The following is a description of a gene set: from publication Chen Y, Wang X (PMID 31504780) species: Homo sapiens Genes predicted to be targets of miRBase v22 microRNA hsa-miR-7856-5p in miRDB v6.0 with MirTarget v4 prediction scores > 80 (high confidence targets). Human Gene Set: MIR7856_5P, and this is the list of marker genes: ARHGAP12, GALNT3, SP3, MRE11, LRIF1, RRAGD, CAMTA1, MCCC2, RWDD2B, SIRT1, DPY19L3, SLC1A4, COPS2, ABCE1, PDCD10, KCNT2, XRN1, UBLCP1, PEX12, DOCK7, KLHL23, HIPK3, NRXN3, SLC12A2, DICER1, ZNF507 (NCBI Gene Id 22847), LRRC19, ZNF414, COBLL1 (cordon-bleu WH2 repeat protein like 1), NUFIP2, TYMSOS, LMBR1, ERBB3, LRAT, ZDHHC21, VPS13C, HEMGN, PRKAA2, THAP2, OGT, CCNJ, TMEM260, GIPC2, PTCHD1, LAMA4, FTMT, ARHGAP18, WDR26, DIXDC1, TMTC4, LIMS1, PTH, SOX9, NANP, USP10, AVL9, QSER1, GLT8D2, KLHL28, FBXO45, VGLL4, CCT8, GPR37, METTL8, GPR22, FSD1L, NEGR1, ZNF705D, CAMK4, GLCE, FZD3, DGKH, VDAC3, NHLH2, PPARGC1B, MAP4K4, MAP3K2, RAB11FIP1, SLC46A3, MOSPD2, USP38, SEH1L, LPAR4, ARK2N, MASP2, FBXO22, RAB3IP, DEFB127 (NCBI Gene Id 140850), AAGAB, GCNT1, MGAT4A, TMTC3, CDH8 (cadherin 8), DARS1, HECTD1, GSS, TWF1, FBXO25, IDE, SMAD5, BMPR2, OARD1, KLF13, ARB2A, GLRB, DDX31, MINDY2, MIGA1, TRPM1 (NCBI Gene Id 4308), WTAP, VAX1, BAG4, LRP6, MOB1B, BZW1, PCDH11Y, PRRG1, DCUN1D5, RAP2A, TMEM108, ARFGEF2, DNMBP, ROBO1, PPP3CB (NCBI Gene Id 5532), DAAM1, EPHA7, PAIP1, RNF216, BBIP1, ETFRF1, CTDSPL2, MCTS1 (NCBI Gene Id 28985), PAQR5, BIRC3, SLC10A7, SRPK2, TTLL7, GUCY1A1, SSR1, ZFHX3, IPCEF1, FNDC3A, ING3, MTERF3, CFL2, ITPR3, SERF2, PTGDR, TIMMDC1, SREK1, KIAA0408, DCUN1D4, RYR3, RBAK, RGCC, MORC1 (NCBI Gene Id 27136), EPHA3, SNX13, TSHR, PURG, GTF2I, HMGXB4, DNAH6, SPRED1, SUZ12, NTRK2, YOD1, FGF12, JPT1, FAM120B, RBPJ, TRAPPC2, TRIM33, ABL2, GABRA4, REV1, RCOR3, GXYLT1, PSEN2, TRIM14, ADGRL3, BACE1, CHD6, NAV3, ELL2, IRS1, TTC21B, SLC41A1, TCEANC (transcription elongation factor A N-terminal and central domain containing), ZNF568, ALCAM, LSMEM2, ARMS2, SLC4A7, FIBIN, KIF16B, CTNNB1, B3GALNT2, SPIN1 (NCBI Gene Id 95616), EIF2S1, MKLN1, CREBZF, RNF2, TRAF6, WASL, PPP1R3A, TRIT1, CNKSR2, MYMX, AK4, RMI1, TRIM9, WDR47, ANKRD13A, RAB30, STARD5, HIVEP1, ZNF546, DCDC1, ENOSF1, XIAP, ARL8B, FOXO1, TNRC6B, GASK1B, ZBTB41, GRIP1, INO80D, SLC50A1, TMX4, MFAP3L, CNTNAP2, CPSF6, MCTP1, NRSN1, ROBO2 (NCBI Gene Id 90370), TBX3, IRS2, AKR1E2, POU3F2, KLHL31, DACH1, DMKN, SCAI, MDGA2, ZNF320, SRPX, RAB40B (RAB40B, member RAS oncogene family), PAQR3, RC3H1, PPP4R3B, TIPRL, RBMY1A1, KLHL14, VMA21, PON2, DRD5, SANBR, RIF1, CASP10, FAM120A, CNTN1, MAPK14, PRRT2, VPS53, ATP11A, RASGRP1, FXR1, GET1, TFEC, RRM2B, MKNK2, KAT6A, DNAJC25, AIDA, SRSF2 (NCBI Gene Id 6427), RGS9, DMXL1, CDC14A, FBP1, GPSM2, PPCS, DRD1, CPE, MBTPS2, MAB21L1, A1CF, GBP3, EIF5A2, PTPN4, HDX, TVP23A, ITM2B, RAP2B, MBOAT2 (membrane bound O-acyltransferase domain containing 2), SCN1A (NCBI Gene Id 6323), C14orf132, RICTOR, FLRT3, ZBTB7A, OSBPL6, TTC22, PIK3C2A, CCNE2, MICAL3, TLCD4, TRIM2, SLC4A4, RBMY1E, ZCCHC14, ZDHHC2, CDC73, REV3L, CDV3, LGALSL, RAD23B, EREG, CDH26, PHF12, THOC2, TMEM237, LRRC58, PCSK6, LRRC7, ARPP19, ELAPOR2, SPOPL, CLOCK, ZYG11B (zyg-11 family member B, cell cycle regulator), HOOK1, IFT57, PDGFRA, DHX40, THRB, NMI, DZIP1, MEAF6, CLUL1, TRABD, BRWD3, VCPIP1, SMIM10, NFIB, RNASE4, RTKN2, SRSF8, GEMIN8, NEXN, F5, KCTD7, SH3RF1, ZNF468, SCN9A, BROX, SHROOM3, PNISR, ICE1, CCDC88A, PANK3, TEX12, SRI, ZBTB43, ZCRB1, CELF4, ACVR2A, SGCD, PLAA, RAP2C, NCOA7, SLFN13, KRAS, UBE2A, GUCY1A2, IRX6, SULT1C4, TGFBR3, RBMY1D, ATP13A3, PPP1CB, EYA4, GNPNAT1, E2F3, YAE1, ITGB8, ACP1, UBFD1, HMGA2, ZBTB6, ZRANB1, SNX18, KLB, CAB39, SRSF1, MRPL17, UNC50, PPP1R9A, GABARAPL1, PCNX1, RBMY1F, COL5A2, PHACTR2, CPEB1 (NCBI Gene Id 64506), TERF2IP, RNF217, PTPN13, RAPGEF6, ETV1, ERP29